Given this list of marker genes GNAQ, BAP1, SF3B1, CYSLTR2, GNA11, here is a description of the gene set: Malignant tumor of melanocytes affecting the iris. Iris melanoma studied in species Homo sapiens Human Gene Set: HP_IRIS_MELANOMA